The following is a description of a gene set: Human Gene Set: GOMF_IMMUNE_RECEPTOR_ACTIVITY Receiving a signal and transmitting it in a cell to initiate an immune response. species: Homo sapiens, and this is the list of marker genes: CNTFR, KIR2DL4, LILRB5 (NCBI Gene Id 10990), FZD4, HLA-DQB1, CXCR6, GFRA2, KLRF1, GPR32P1, IL5RA, CXCR2, FPR1, GFRA3, CCR4, KLRC2, GPR35, MR1, HLA-DOB, IL12RB2, IL17RC, C3AR1, IL22RA1, FCGR1BP, CSF2RB, NCR3, FCGR2C, FCGR2B, FCMR, HLA-DOA, IL1RAP, CMKLR1, PIGR, ACKR2, IL20RA, IL2RG, LILRA1, CTSH, IL17RE, CX3CR1, LEPR, ACKR3, CCR10, IL1RL1, FCGR3B, HLA-DQA1, HLA-DQA2, GFRA4, LILRA6, FCER2, IL3RA, HLA-DQB2, EPOR, IL9R, GPR32, CRLF2, IL10RB, CR2, IL1RAPL2, IFNAR1 (interferon alpha and beta receptor subunit 1), CD44, IL6ST, KIR2DS5, FLT3, LILRB4, IL11RA, GPR33, ACKR4, GHR, LILRB1, CCR3, CXCR4, IL21R, IFNAR2 (NCBI Gene Id 3455), CCR9, CCR5, IL20RB, GFRAL, CCR7, IL13RA1, IL1R2, CD160, IL31RA, IL15RA, CCR6, IL17REL, GFRA1, IL4R, CRLF1, KLRD1, C5AR1, IL7R, IL6R, FCER1G, IL18RAP, KIR3DS1, IL2RA, IFNGR1, CSF3R, FPR2, IL2RB, CR1 (NCBI Gene Id 1378), IL22RA2, MPL, FCGR1A, GPR75, LILRB2, IL17RA, LILRA2, IL1RL2 (interleukin 1 receptor like 2), IL13RA2, FCER1A, IL12B, LILRA3, LILRB3, HLA-DPA1, XCR1, KLRC4-KLRK1, IL1R1, C5AR2, IL18R1, CD200R1, KIR3DL1, IL10RA, KLRK1, IL12RB1, FCGR2A, LIFR, CD74, CCRL2, CXCR1, GPR17, CSF2RA, CCR1, IL17RD, LILRA4, CCR2, HLA-DRB3, IFNGR2, FPR3, PRLR, IFNLR1, IL23R, CXCR3, KLRC1, IL27RA, IL17RB, HLA-DRB1, HLA-DRA, CXCR5, CCR8 (NCBI Gene Id 1237), FCAR, CD4, F3, OSMR, FCGR3A, EBI3, LILRA5